Given this list of marker genes Rps25, Rps9, Eif3i, Eif3f, Rps23, Rps2, Rps20, Eif3g (NCBI Gene Id 53356), Rps18 (ribosomal protein S18), Eif1ax, Eif4a2, Eif3j2, Eif3k, Pabpc1, Eif3d, Rps12, Fau (NCBI Gene Id 14109), Rps27l, Eif3b, Rps4x, Eif4a1, Eif2s3x, Eif3e, Rps7, Rps19, Rps15, Eif4ebp1, Rps10, Rps26, Rps28, Rps3a1, Rps8, Rps17, Rps6, Rps13 (NCBI Gene Id 68052), Rps24, Rps5, Rps11, here is a description of the gene set: This event has been computationally inferred from an event that has been demonstrated in another species.<p>The inference is based on the homology mapping from PANTHER. Briefly, reactions for which all involved PhysicalEntities (in input, output and catalyst) have a mapped orthologue/paralogue (for complexes at least 75% of components must have a mapping) are inferred to the other species. species: Mus musculus Reactome Pathway: Activation of the mRNA upon binding of the cap-binding complex and eIFs, and subsequent binding to 43S part of: Cap-dependent Translation Initiation electronically inferred by orthology from the curated human pathway